The following is a description of a gene set: species: Homo sapiens Genes having at least one occurrence of the motif TTTCSCGC in the regions spanning 4 kb centered on their transcription starting sites. This matches the E2F4, TFDP2 transcription factor binding site V$E2F4DP2_01 (v7.4 TRANSFAC). Human Gene Set: E2F4DP2_01, and this is the list of marker genes: GLRA3, TRA2B, H2AZ2, NABP2 (nucleic acid binding protein 2), ZCWPW1, NELL2, UGGT1, APH1A, H2AZ1, GABRB3, NRK, ARID4A, HMGXB4, NIPBL, RMI2, PEG3, RBL1, ACBD6, MTF2, CNOT9, DLG3, MAP3K7, SPINK5, APPL1, DNAJC5G, ZNF565, H2BC12, MCM6, DCK, NFATC2IP, E2F7, CDC20B, HNRNPD, ZNF367, WDR62, EED (embryonic ectoderm development), FANCG, JADE2, GINS3 (GINS complex subunit 3), NASP, MCM3, KANSL3, ZNF644, UBR7, SASS6, SMAD6, NR6A1, ARHGAP11A, PHC1, POLE2, PCIF1, PRP4K, SRSF7, MXD3, SLCO3A1, CBX3, MCM4, KCNA6 (potassium voltage-gated channel subfamily A member 6), FMO4, RAVER1, POLD3, SLITRK4, SUMO1, EMC3, TAOK2, ACO2, GON7, SEMA6A, SP3, ZCCHC8, WBP2NL, FIZ1, NUP62, POLD1, MSH2, ATF5, ALDH6A1, FANCD2, TMEM187, TMEM143, CDC5L, CDK1, YTHDC1, ZIM2, H2AC12, LUC7L3, EIF4A1, KCNS2, E2F3, MYC, EFNA5, TRMT2A, HNRNPUL1, PAX6, GAPDH, SUV39H1, MAPT, CORT, AP4M1, ZNF524, MCMBP, TLE3, OTUD7B, PODN, ADAMTS2, MAZ, PRPS1, NCL, CTDSPL2, HOXC10, SYNGR4 (synaptogyrin 4), PAN2, PAQR4, STMN1, BRME1, FKBP5, VCAN, MAPK6, TFAP4, HS6ST3 (NCBI Gene Id 283476), GATA1, MSH5, RRM2, IPO7, FANCC, IL4I1, SPTB, AP1S1, EZH2, ATAD5, ZNF687, POLR1G, SLC9A7, HNRNPR, PHF5A, SMC6, KBTBD6, HNRNPA2B1, PTMA, PBRM1, PCNA, RPS20, GSPT1, DMD, DNMT1, MEPCE, GPRC5B, CDC6, GRIA4, TYRO3, BRPF1, ING3, ID3 (inhibitor of DNA binding 3), CLSPN, PKMYT1, POLE4, MCM7, HMGA1, KBTBD7, PLAGL1, RANBP1, STAG1, SMC1A, SYNCRIP, PCLAF, DNAJC9, NUFIP2, ILF3-DT, EHBP1, TMEM108 (transmembrane protein 108), EPHB1, POU4F1, AK2 (NCBI Gene Id 83165), CDC25A, ATAD2, PPM1D, SOAT1, MCM2, H4C1, ARHGAP6, KMT5A, CAND1, PPIG, H3C1, UNG, PIM1, TBX6, ILF3, IER5L, CDCA7, KIAA0825, PRKDC (protein kinase, DNA-activated, catalytic subunit), GEN1, POLR2A, DCTPP1, TRIM39, RPS6KA5, GMNN, ZNF362, GPBP1, HCN3, TRMT6, MYH10, EMSY, USP37, CCNT1, NOLC1, RASAL2, ZNF503, RTBDN, JADE1, RIBC1, TRMT13, CASP8AP2, STT3B, POLA1, SRSF1, SNRPD1, SMC3, STK35, FBXO5, ASXL2, YBX2, HIRA, TMPO, RET, PCSK1, SLC9A5, MRPL40, MCM8, E2F1, ZBTB4, THAP8, E2F8, BRMS1L, FHOD1, TOPBP1, PRPS2